The following is a description of a gene set: species: Homo sapiens Human Gene Set: GOBP_REGULATION_OF_TOLL_LIKE_RECEPTOR_9_SIGNALING_PATHWAY Any process that modulates the frequency, rate, or extent of toll-like receptor 9 signaling pathway., and this is the list of marker genes: RAB7B, PTPRS, FCRL3, TLR9, LILRA4, RSAD2, HMGB1, RTN4, ZDHHC3, PPT1, SLC15A4, GRAMD4